Given this list of marker genes TCIRG1, SLC4A7, RAB39A, RAB7A, RAB38, RAB20, SLAMF8, here is a description of the gene set: Any process that reduces the pH of the phagosome, measured by the concentration of the hydrogen ion. Human Gene Set: GOBP_PHAGOSOME_ACIDIFICATION studied in species Homo sapiens